The following is a description of a gene set: human blood monocytes were isolated, activated and harvested at several timepoints In this study, we identified genes that were differentially expressed in human monocytes activated with eiter NOD2L and/or TLR2/1L. studied in species Homo sapiens Human Gene Set: GSE34156_UNTREATED_VS_24H_NOD2_LIGAND_TREATED_MONOCYTE_DN Genes down-regulated in monocytes (24h): untreated versus muramyl dipeptide. from publication Schenk M, Krutzik SR, Sieling PA, Lee DJ, Teles RM, Ochoa MT, Komisopoulou E, Sarno EN, Rea TH, Graeber TG, Kim S, Cheng G, Modlin RL (PMID 22447076), and this is the list of marker genes: FBXO42, RAB31, CD14, SIRPA, ASPH, SYNGR2, CXCL16, ABCA1, UBE2Z, WDFY3, SESTD1, EPB41L3, LGALS9, CD300LF, ZNF697, MPEG1, LILRB1, VPS33B, CARD19, TALDO1, SLC16A6, SLC8A1-AS1, ARHGEF2, CD8B, GNB4, CD163, MFSD1, DOK3, NID1, VCAN, FCGR2C, CSF2RB, PLCXD1 (NCBI Gene Id 55344), PILRA, LY96, BRI3, MED11, GLT1D1, ALDH3B1, FAM234B, FAM20C, SWAP70, COPRS, CYBB, PRG2, CYP27A1, SIGLEC9, ADRA2A, HCK, LINC01854, LILRB4, TMEM51, LGALS3, TMEM170B, ATP6V1B2, NKX6-1, IRF5, LGALS1, VDR, VPS26A, ANPEP, PTPRE, NLRP12, CD86, KDM1B, TMEM98, XKR4, GRN (NCBI Gene Id 2896), NCF4, MNDA, TPRXL, NCOA4, LILRB2, FTL, PANX1, GK3, NADK, SLC31A2, HS3ST3B1, TCF4, PTPN6, MBOAT7, HPSE, PITPNA, EMILIN2, MYOF, RAB7A, GASK1B, MPP1, PSTPIP2, DMXL2, VEGFA, RP2, CXCL1 (NCBI Gene Id 2919), ADAM28, UNC45B, NDUFB4, OS9, H1-0, ALAS1, SLC11A1, DIP2B, DOC2B, SRC, BYSL, CLIC4, GPR157, KCNJ2, NRP2, DAPP1 (dual adaptor of phosphotyrosine and 3-phosphoinositides 1), HLA-DRB4, GLUL, TIMP2, TNS3, GABARAP, WARS1, SLC25A37, MAP4K3, TRPS1, GRTP1, TGFBI, BATF3, CSF2RA, CNPY3, RAB20, VPS37C, NCF2, MANBAL, NR1H3, RAC1, SULF2, CORO1C, HLA-DMB, WDR41, ZBED5, TSC22D1, ZNF385A, MOB1B, ASAH1, ADGRE2, LIN7A, RAD51C, TMF1, CTNNA1 (catenin alpha 1), CREG1, GK, LMO2, CAPZA2, FPR2, PTAFR (NCBI Gene Id 91527), RHOU, OMG, IFI30, PPP3R2, BICC1, MGST1, GRINA, LGALS2, ZNF100, C15orf48, TFEC, IDH2, KCTD12, CHST15, METTL22, KYNU (NCBI Gene Id 8942), CSF1R, GPX1, IGSF6, SRA1, ADAM9, TPP1, LHFPL2, PGD, RBM19, PLAU, LILRB3, ADM, ANXA5, AOAH, GM2A, SAT1, SEH1L, RAB12, SMIM3, NOP10, NPC2, IL13RA1, BCAT1, MSL3, RBM47, GCA, GSDME, LYSET (NCBI Gene Id 26175), FCGR2A, DOCK4, DSE, PDCD10 (NCBI Gene Id 9226), PSMB1, TMEM127